The following is a description of a gene set: Human Gene Set: GOBP_PROTEIN_MATURATION studied in species Homo sapiens Any process leading to the attainment of the full functional capacity of a protein., and this is the list of marker genes: AZU1, B2M, CTSG, CTSL, FKBP5, LONP2, HSPA5, DHCR24, DOHH, VAPA, HSPA13, CDC37, TMEM260, CASP6, GALNT2, HSPA4, FKBP9, P4HB, PRKACA, TBCA, PFDN5, APH1A, PDCL3, PDIA3, CDC123, NPPC, NAA60, LMAN2L, DPP4, APCS, NUDCD2, UNC45B, CISD1, HSP90AA1, SH3GLB1, COMP, PIGQ, PLAUR, NAA10, PDILT, PCSK7, ERP44, DNAJC3, HP, TCP1, KLK8, ANP32E, F13B, TXNDC5, HSP90AA2P (heat shock protein 90 alpha family class A member 2, pseudogene), SPCS2, SEC11C, PISD, AFG3L2, PCSK4, KLK2, NAA16, DNAJA4, DNAJC18, HSPD1, EP300, TAPBP (TAP binding protein), CCT8, PLGRKT, TBCEL, RIC3, DNAJC5 (DnaJ heat shock protein family (Hsp40) member C5), SEC11B (NCBI Gene Id 648643), SELENOF, SPCS3, FKBP10, TELO2, PRSS12, PPIAL4H, TMPRSS4, SHH, HSPA1B, GP9, PDIA2, PPIA, KLK11, HSP90B1 (NCBI Gene Id 7184), PSENEN, POFUT2, VBP1, FAM111A, PIGX, USP17L2, CDK20, KLK15, HID1, SERPINF2, FKBP11, TOR2A, NFYC, KLKB1, ANXA2, SDHAF4, TNP2, CALR3, MIPEP, NUDC, PPIF, IHH, CCT3, TTC1, CMA1, MAGEA3, BAG4, CASP8, AIFM1, PGAP3, ERO1A, VSIR, FGG (NCBI Gene Id 2266), SLC30A8, NNAT, F9, GLRX5, CCS, KLK14, NAGLU, CCT4, STOML2, BOLA3, PPIH, ISCA2, MELTF, METTL21A, PRDX4, QSOX2, ADAM19, ZMYND10 (zinc finger MYND-type containing 10), CPE, CREBBP, TNP1, DNAJC1, GZMA, PIGA, TBCB, CCT7, HJV, PHEX, SIL1, CHCHD4, ADAMTS3, WIPF1, PARP1, DNAJC25, THBS1, PIGZ (phosphatidylinositol glycan anchor biosynthesis class Z), NPPA, FKRP, PDCL2, FKBP1B, LMAN1, IMMP1L (NCBI Gene Id 196294), CPZ, IFT52, PEX19, FKBP6, FLNA (NCBI Gene Id 8272), HPR (NCBI Gene Id 3250), KLK9, DNAJB13, DNLZ, ST13 (NCBI Gene Id 8937), ZMPSTE24, CPA3, GGT2P, LYRM7, PDRG1, RNF139, GP1BB, PSEN1, PPIAL4A, CLGN, RP2, SDF2, CALR, THBD, ACE2, PIGP, SACS, HSP90AA4P, SERPINH1, DNAJA1, PMPCB, TYSND1, C1R, PRCP, KAT2B (lysine acetyltransferase 2B), P2RX7, DNAJB6, PIK3C3, HYOU1, LIPT2, ADAMTS2, CASP1, DNAJC19, DNAJB11, PIGV, PRSS57, RANBP2 (NCBI Gene Id 5903), SNRNP70, DNAJB7 (DnaJ heat shock protein family (Hsp40) member B7), MPDU1, DPM3, PLA2G7 (NCBI Gene Id 7941), PIGH, F3, DFFA, CLN3, GP1BA, PPWD1, SRC, SPCS1, ATG4D, MBOAT4, CANX, PIGF, HSPE1, PCSK5 (proprotein convertase subtilisin/kexin type 5), NKD2, PFDN4, TSPAN14, FBLN1, TRAP1, ERP29, CCT8L2, KLK1, GZMM, ANGPTL8, TBCC, ASPRV1, ACTMAP, DNAJB8, RPS6KA2, DPM1, DNAJB2, DHPS, CHORDC1, PDIA6, PFDN1, BAG5, MMS19, TMPRSS2, ITGB3, DNAJA3, RCE1, RASAL2, RNF123, F11 (coagulation factor XI), BAG3, CLEC3B, MKKS, ATG4B, C2CD3, PIGM, PGK1, HSP90AB2P, BAG2 (NCBI Gene Id 9532), IKBKB, FGB, APLF, CCT6B, ADAM10, PLG (NCBI Gene Id 90749), MBTPS2, GPAA1, HSPB2, NAA11, PCSK9, MYC, KLK5, ADAM17, ANPEP, AIP, YAE1, CWC27, NLRP3, LRRK2, RIC8A, AHSP, CD74, CCT8L1P, F13A1, ACE, PRSS58, TSC1, AKT1, GLG1, ATP23, GFER, PREP, ADAM8, PFDN2, CDC37L1, TBCD, CCBE1, ERO1B, DNAJB4, CORIN, HSPA1A, KLK7, HPN, PIGS, KLK12, KLK13, ENPEP, CPLANE2, CIAO2A, MDM2, SIRT4, CPM, MMP16, MYRF, MPPE1, PIGK, CASP2, PIGU, HSPA2, UGGT1, ENO1, HSPA1L, HSPA4L, DNAJB5, LTBP4, RAP1GDS1, C1RL, NAA15, CSNK2A1, PPIB, RIC8B, HYPK, ELP6, HSP90AB4P, CIAO1, PCSK1N, PLAT, YME1L1, AANAT, ENTPD5, HSPA7, PITRM1, CPN1, ALG12, PRNP, DUOXA2, PGAP2, GRN, GRPEL2, NAA20, CAPN2, DNAJB12, PIGN, FGA, PPIG, FKBP1A, KLK4 (kallikrein related peptidase 4), BACE1, PIGB, FURIN, PPIAL4F, CLPX, RUVBL2, CWH43, ACP4, MAFB, ECE2, BOLA2B, EEF1AKMT4-ECE2, CRYAA, CASP4, SERPINE2, APH1B, PCSK6, MMEL1 (NCBI Gene Id 79258), KEL, DYNC2H1, ATP7B, GZMK, KLK6, TESC, DDI2, DNAJC7, ATG4A, CTSS, ECE1, SNX12, FUT10, MEP1A (meprin A subunit alpha), IFT172, PTCH1, METAP1, ATG4C, CTSZ, MME, LTO1, CASP10, GP5, PRSS3, HSP90AB3P, HSP90AA5P, CASP9, ERP27, WDR83OS, CASP5, FTMT, ARL2, SRGN, TBCE (tubulin folding cofactor E), PIGW, ZPR1, SDF2L1, CASP3, PRPH2, NLRC4, CIAO2B, LMF2, GZMB, HSPB1, CCDC47, F12, CISD3, NPPB, PPIAL4D, MBTPS1, HSPA8, DNAJC21, PDCD5, ECEL1, GLI3, ZNG1E, TMPRSS12, IL1R2, BCHE, PIGL, FKBP4, FKBP2, NAA50, SPON1, SPPL3, FKBP8, PPIC, HSPB6, PDIA5, TMEM98, PIGT, APOH, CPD, PCSK1, BACE2, ISCA1, PCSK2, PPIE, MYRFL, GSN, SLC30A5, CLN5, S100A10, FXN, PPIL1, LDLRAD3, ATF6, PLAU, TFR2, ASTL, NLRP7, TLL1, PIGC, CFD, HSP90AB1, BAG1, NAA80, SCG5, YIPF5, METAP2, QSOX1, CCT6A, MMP14, H2BC1, INPP5B, SDE2, FNTA, PPIAL4G, ATP6AP2, NGLY1, DNAJB14, DNAJC24, MIR152, GGCX, TMEM208, PRSS37, KHSRP, MVP, PSEN2, TSPAN5, PIDD1, SPG7, HGFAC, DNAJC4, DISP1, RFX4, DNAJC10, TOR1B, HSPA6, PIGG, PTGES3L (NCBI Gene Id 100885848, prostaglandin E synthase 3 like), KLK10, MYH9, ADAMTS13, BMP1, LMF1 (lipase maturation factor 1), DNAJB3 (NCBI Gene Id 414061), OGT, TASP1, DNAJC2, PPIAL4C, DPM2, DNAJA2, TLL2, DHH, RHBDD1, PMPCA, PDIA4, AHSA1, CUZD1, CRTAP, TOR1A, F8, HSPA14 (NCBI Gene Id 51182), NKTR, NFU1, NCSTN, HSP90B2P, UMOD, KLK3 (kallikrein related peptidase 3), UBAC1, CHAC1, PPIAL4E, PGAP4, CSTL1, PTGES3 (NCBI Gene Id 10728), HSPA9, NDUFAB1, PPIL2, GRPEL1, P3H1, HSPH1, PARL (presenilin associated rhomboid like), AASDHPPT, PFDN6, MOGS, IMMP2L, HM13, PGAP1, OMA1 (OMA1 zinc metallopeptidase), AHSA2P, CRYAB, F7, AEBP1, TSPAN33, SERPINE1, PIGO, CASP7, CCT5, CTSH, MESD, GZMH, PIGY, PPIL3, TTC4, UNC45A, HSPBP1, RUNX1, CCT2, SPRTN, ENGASE, ADAM9, GGT1, SNAPIN, GAK (NCBI Gene Id 2580), NUDCD3, PPID, GAS1, TSPAN15, CLU (NCBI Gene Id 1191), BOLA2, REN, PRKACB, CNTN2, SEC11A, DNAJB1, UFSP1, HTRA2, LGMN, XPNPEP3